Given this list of marker genes CCDC102B, TAGLN, SEPTIN7P2, APOL5, NDUFA4L2, KCNMB1, AVPR1A, GPAT2, CYGB, ACTA2-AS1, ACTG2, MEF2B, COX4I2, EBF2, CSPG4, COL6A3, ADGRA3P1, GPR20 (NCBI Gene Id 2843), GJC1, CNTNAP1, TACR2, RFX8 (regulatory factor X8), ADCY3, MYH11, RASL12, TMEM74B, LAMC3, MDFIC2, NOTCH3, TBX2, THBS4, CCR10, PLA2G5, HIGD1B, AOC3, PDGFRB, MYLK, ANO1, WNT3A, ACTA2, ABCC9, KCNJ8, SEPTIN4, CARMN, here is a description of the gene set: Human Gene Set: DESCARTES_MAIN_FETAL_SMOOTH_MUSCLE_CELLS from publication Cao J, O'Day DR, Pliner HA, Kingsley PD, Deng M, Daza RM, Zager MA, Aldinger KA, Blecher-Gonen R, Zhang F, Spielmann M, Palis J, Doherty D, Steemers FJ, Glass IA, Trapnell C, Shendure J (PMID 33184181) Marker genes curated from the annotated cluster as represented in the Descartes Human Gene Expression During Development database. The gene expression program underlying the specification of human cell types is of fundamental interest. The study authors generated human cell atlases of gene expression and chromatin accessibility in fetal tissues. For gene expression, the study authors applied three-level combinatorial indexing to >110 samples representing 15 organs, ultimately profiling ~4 million single cells. The study authors leveraged the literature and other atlases to identify and annotate hundreds of cell types and subtypes, both within and across tissues. Our analyses focused on organ-specific specializations of broadly distributed cell types (such as blood, endothelial, and epithelial), sites of fetal erythropoiesis (which notably included the adrenal gland), and integration with mouse developmental atlases (such as conserved specification of blood cells). These data represent a rich resource for the exploration of in vivo human gene expression in diverse tissues and cell types. species: Homo sapiens